The following is a description of a gene set: from publication Cui A, Huang T, Li S, Ma A, Pérez JL, Sander C, Keskin DB, Wu CJ, Fraenkel E, Hacohen N (PMID 38057668) studied in species Mus musculus Cytokines mediate cell-cell communication in the immune system and represent important therapeutic targets. A myriad of studies have highlighted their central role in immune function, yet we lack a global view of the cellular responses of each immune cell type to each cytokine. To address this gap, the authors created the Immune Dictionary, a compendium of single-cell transcriptomic profiles of more than 17 immune cell types in response to each of 86 cytokines (>1,400 cytokine-cell type combinations) in mouse lymph nodes in vivo. A cytokine-centric view of the dictionary revealed that most cytokines induce highly cell-type-specific responses. For example, the inflammatory cytokine interleukin-1β induces distinct gene programmes in almost every cell type. A cell-type-centric view of the dictionary identified more than 66 cytokine-driven cellular polarization states across immune cell types, including previously uncharacterized states such as an interleukin-18-induced polyfunctional natural killer cell state. Genes positively differentially expressed in cell type: B cell upon treatment with cytokine: IL-17E in mouse lymph nodes in vivo. Mouse Gene Set: CUI_B_CELL_IL17E_RESPONSE_UP, and this is the list of marker genes: Hif1a, H2-Aa, Ap1m1, Cirbp, Oat, Nr2c2ap, R3hdm4, Smndc1, Isca2, Fxr1, Bccip, Selenof, Rnf130, Kdelr1, Vamp4, Ptp4a1, Hspa14, Sec23b, Hspa9